Given this list of marker genes TNFSF4, IL10, PRNP, PGLYRP1, HLA-DRB1, AXL, ZNF683, LGALS9, LGALS9B, HMGB1, SCGB1A1, LILRB4, LAPTM5, HAVCR2, IRGM, GAS6, LILRB1, GATA3, MIR24-1, NR1H4, C1QBP, INHBA, PGLYRP3, IL33, IL20RB, LGALS9C, MIR708, DDIT3, CD274, INHA, NLRP6, SLAMF1, XCL1, FOXP3, IL36RN, ZC3H12A, PGLYRP2, PDCD1LG2, TLR4, CD96, VSIR, RARA, IL1RL1, CR1, here is a description of the gene set: Any process that stops, prevents, or reduces the frequency, rate, or extent of interferon-gamma production. Interferon-gamma is also known as type II interferon. Human Gene Set: GOBP_NEGATIVE_REGULATION_OF_TYPE_II_INTERFERON_PRODUCTION species: Homo sapiens